Given this list of marker genes Ube2q2l, Cpne8, Gphb5, Nfkbid, Zfp985, Foxk1, Arl14ep, Rnf38, Fbxo42, Plekhg4, Tacr3, Zfp820, Kifbp, Ankrd45, Igf2bp2, Adam10 (a disintegrin and metallopeptidase domain 10), Veph1, Pomgnt1, Runx1, Ap3s1, Mfap4, Camk2d, Umps, Nip7, Zfp143, Nkiras2, Scaf11, Stn1, Ceacam18, Zfp268, Luc7l2 (LUC7-like 2 (S. cerevisiae)), Rtn4, Sppl2a, Nkd2, Ahnak, Nhsl2, Bet1, Vstm2a, Cux2, Ppp2ca, Csgalnact1, Gje1, Gls, Tmem200a, Gnptg, Ppm1n, Ms4a6c, Ythdf1, Cd1d1, Zfp984, Uqcc5, Ttc17, Nasp, Sumo1, Arsk, Jaml, Mtmr4 (NCBI Gene Id 170749), Prkca, Klra7, Ccdc91, Avl9, Plekha7, Apol10a, Ipo5, Tbx6, Itpripl1, Tgm6, Zfp987, Garin3, Ilf3, Gimap4, Cyp4f15, Zfp599, Arhgef17, here is a description of the gene set: from publication Chen Y, Wang X (PMID 31504780) studied in species Mus musculus Genes predicted to be targets of miRBase v22 microRNA mmu_miR_3068_5p in miRDB v6.0 with MirTarget v4 prediction scores > 80 (high confidence targets). Mouse Gene Set: MIR_3068_5P